The following is a description of a gene set: Any process that modulates the frequency, rate or extent of fatty acid bbeta-oxidation. Mouse Gene Set: GOBP_REGULATION_OF_FATTY_ACID_BETA_OXIDATION studied in species Mus musculus, and this is the list of marker genes: Dbi, Mtln, Mlycd, Abcd2, Acsl5, Akt1, Plin5, Akt2, Cnr1, Lonp2, Fabp1, Acacb, Irs1, Etfbkmt, Abcd1, Cpt1a, Tysnd1, Abcb11, Obp2a, Mtor, Irs2, Mfsd2a, Twist1